The following is a description of a gene set: studied in species Homo sapiens from publication Newell KA, Asare A, Kirk AD, Gisler TD, Bourcier K, Suthanthiran M, Burlingham WJ, Marks WH, Sanz I, Lechler RI, Hernandez-Fuentes MP, Turka LA, Seyfert-Margolis VL, Immune Tolerance Network ST507 Study Group (PMID 20501946) Genes up-regulated in periperal blood monocytes (PBMC): kidney transplant recipients receiving immunosuppression therapy versus healthy controls. Human Gene Set: GSE22229_RENAL_TRANSPLANT_IMMUNOSUPP_THERAPY_VS_HEALTHY_PBMC_UP In this study, investigators recruited the largest reported cohort of tolerant kidney transplant recipients who maintained their graft after ceasing to take their immunosuppression drug, and compared this cohort to subjects with stable allograft function while on immunosuppression and healthy non transplated, controls. Using gene expression studies, they identified genetic markers that are strong candidates for predicting kidney transplant candidates who may benefit from minimization or withdrawl of immunosuppression. Microarrays were used to detect expressed gene profiles of whole-blood total RNA from subjects in the tolerant, standard immunotherapy and healthy control participants, and this is the list of marker genes: ABCF2, C8orf76, BID, SGMS2, SLC2A6, PARP1, OCIAD1, BLNK, LMO4, ARF1, PGAM1, B4GALNT1, PTGR1, EIF2S2, KBTBD8, DIS3, PECAM1, FANCL, TYMS, RASGRP4, ALG10, NUP93, KARS1, MOGS, REEP1, BCL11B, KATNBL1, CKAP2, PHF5A, INTS14, TMED10, EPN3, BCKDHB, FCER1G, SLAIN2, AOAH, SLC35B1, KLF4, CHGA, TXNDC11, DLST, PROM1, DOCK8, CXCR4, MRPL21 (mitochondrial ribosomal protein L21), OSTF1, XDH, NFIL3, DMAC1, APPBP2, LTA4H, REV1, GFM1, DNAJB11, ERCC8, AUNIP, CDC45, ITGA1, NUDT19, CLEC7A, RNPEP, SVIP, CD68, MACROH2A1, C6orf118, HVCN1, STAU1, OLR1, RASSF4, PDSS1, SSR4, RALB, TIMD4, USP14, LBP, NRG1, FES, RASA4, CENPE (centromere protein E), ECHS1, IFNGR2, RPS6KA2, SNUPN, PAPSS2, TMEM184C, KIAA0930, BNIP2, TDP1, YME1L1, STXBP6, PRIM2, TIFA, PUS10, ANGPTL2, LAP3, ETFB, SNX9, DNAJC9, GINS1, BOD1, CCT2, TMEM229B, UBASH3A, NASP, EGLN3, RAMP1, LIPI, COQ3, LNX2, NR2E1, DGKB, SOWAHC, TXNDC5, ABCA9, HCK (HCK proto-oncogene, Src family tyrosine kinase), MAOA, SLPI, AKIRIN1, GMFG, PI16, TUBA3C, SMARCE1, IL7R, MARS1, GMCL1, DDX56 (DEAD-box helicase 56), GSPT1, PSMB4, OSCP1, HERPUD1 (homocysteine inducible ER protein with ubiquitin like domain 1), PALS2, MRPL46, PSMC6 (proteasome 26S subunit, ATPase 6), SKA1, TYROBP, LTV1, IDH1 (NCBI Gene Id 3417), ITGB7, TLR7, CRELD2, ZNF658, SAA1, CEBPA, FABP5, SHISA2, ORC6, P4HB, MCM8, MTCH2, TMA16, DHRS3, MEFV, ELANE, SRSF3, RHBDL3, FNBP4, PRPF38B, SLC16A1, HPSE, SLIT1 (NCBI Gene Id 6585), UBE2W, NAA25, BLOC1S6 (NCBI Gene Id 26258), CERS6, ILF2, DDX21, NAGPA, MAT1A, RSL1D1, PSTPIP2, TENT2, COMMD7, AIM2, SLC46A1, FCRL1, SEC24D, FIG4, UFL1, C3, COMMD2, FCGR2A, RPP14, CRY1, ERO1B, PLOD3, PSMA4, MAPKAPK2, EIF2B1, CDADC1, CX3CR1, TMC8, CLDN15, STX7, OPN3, MINDY3, AGPS, PSMC4, PLA2G15, SCCPDH (NCBI Gene Id 51097)